Given this list of marker genes ICOS, CCR7, FCGR3A, CCL21, IRAK1BP1, CCL18, LAMP3, CCL19, PYCARD, CARD10, NOD1, CARD9, IRAK1, CCR4, ICAM1, B2M, CCL20, CD83, CCR6, TICAM1, TAP2, here is a description of the gene set: Human Gene Set: FULLER_PBMC_F_TULARENSIS_VACCINE_LVS_AGE_22_54YO_18HR_DN Genes down-regulated in peripheral blood mononuclear cell 18hr vs 0hr in adults (22-54) after exposure to F. tularensis vaccine LVS, time point 18H from publication Fuller CL, Brittingham KC, Porter MW, Hepburn MJ, Petitt PL, Pittman PR, Bavari S (PMID 17349694) studied in species Homo sapiens The live vaccine strain (LVS) of Francisella tularensis is the only vaccine against tularemia available for humans, yet its mechanism of protection remains unclear. We probed human immunological responses to LVS vaccination with transcriptome analysis using PBMC samples from volunteers at time points pre- and post-vaccination. Gene modulation was highly uniform across all time points, implying commonality of vaccine responses. Principal components analysis revealed three highly distinct principal groupings: pre-vaccination (-144 h), early (+18 and +48 h), and late post-vaccination (+192 and +336 h). The most significant changes in gene expression occurred at early post-vaccination time points (<=48h), specifically in the induction of pro-inflammatory and innate immunity-related genes. Evidence supporting modulation of innate effector function, specifically antigen processing and presentation by dendritic cells, was especially apparent. Our data indicate that the LVS strain of F. tularensis invokes a strong early response upon vaccination. This pattern of gene regulation may provide insightful information regarding both vaccine efficacy and immunopathogenesis that may provide insight into infection with virulent strains of F. tularensis. Additionally, we obtained valuable information that should prove useful in evaluation of vaccine lots as well as efficacy testing of new anti-F. tularensis vaccines.